Given this list of marker genes TMPRSS15, MAOA, STAR, PTGS2, MAOB, VIPR1, AOC3, PPBP, PF4, ARHGAP22, ADGRL4, here is a description of the gene set: studied in species Homo sapiens Human Gene Set: MODULE_557 Genes in the cancer module 557.